Given this list of marker genes AGO1, BCR, MAPK8IP3, PRKDC, SMC3, TPR, CEP152, NAA80, PGAP3, MAPK1, OTUD6B, MAN1B1, WDR62, CDH11, AHDC1, OCA2, KCNJ2, SNRPN, THUMPD1, KATNB1, SHMT2, HDAC8 (histone deacetylase 8), MCPH1, TLK2, BCL11B, PIGG, SATB2, OCRL, LMBRD1, CHST14, WARS2, PDE4D, CRKL, TRPS1, ACBD6, HERC2, POGZ (NCBI Gene Id 23126), GAD1, AGL, PWAR1, KAT6A, TAF13, B3GLCT, PLPBP, PRKAR1B, TRRAP, ADAMTSL2, WAC, MED12L, TRAPPC10, IGF1R, TTC5, RNU4ATAC, CIT, ASCC3, WARS1, CEP63 (NCBI Gene Id 80254), SH3PXD2B, UBE3B, EBF3, CDK13, PIGV, TRMT10A (tRNA methyltransferase 10A), SLC6A1, KNL1, MBD5, ZNF526, NALCN, CDH2, UNC80, STT3A, SMARCC2, IFT43, TBL1XR1, PPP1CB, VPS35L, MKRN3, EIF5A, KCNMA1, KIF15, ATN1, ATRX, HK1, B4GALT1, SPECC1L, IFIH1, SRRM2, AMMECR1, PQBP1, PBX1, KAT6B, ANKRD11, MAGEL2, AARS1, SRCAP, PIGQ, PAK3, CDK10, KMT2D, ZNF407, SOX11, PHC1, AFF3, ATP6V1B2, PDGFRB, CTCF, PACS1, NCAPD3, ARMC9, SMARCB1, MPC1, ANKRD17, FAR1, METTL5, NIPBL, DHPS, MFSD2A, CDC42, TMEM147, CENPE, ACTG1, BMP2, ASXL2, AFF4, KDM5C, PURA, CNTNAP2, H4C5, CLTC, ARID1A, HIVEP2, GLIS3, MED12, NEXMIF, PIGU, COPB2, ADNP, DVL1, NAA10, BCL11A, MTOR, GNB2, CCNQ, PITX2, SMARCE1, ANKLE2, CLCN6, KIF14, RNF135, HNRNPC, SETD5, ALG12, TBCE, ALG9, CPLX1, AGR2, ZNF292, CEP295, BPTF, SPTBN1, CDC42BPB, SPEN, MED13, TBC1D24, ADGRG6, BUB1, SOX4, CHD2, USP9X, WASHC4, PUF60, KMT2A, ASPM, CASP2, NONO, KDM1A, GNAI1, OPHN1, CCNK, ZFX, FBN1, MCM7, PPP2R5D, EXT1, GJA5, RAP1B, SMARCD1, MEIS2, ARID1B, NPAP1, LAS1L, UBAP2L, AP3B1 (NCBI Gene Id 8546), SIM1, CREBBP, PTRH2, MCTP2, STIL, SMC1A, FIG4, CLP1, TAF6 (NCBI Gene Id 6878), WDR19, RNU4-2, ARX, PIEZO2, WDR26, PIGK, HS2ST1, VPS51, EP300, DCPS, SYNGAP1, FGFR2, DSE, CUX1, PYCR2, PGM2L1, DHX9, KDM3B, KDM6A, GATAD2B, PWRN1, MEF2C, POLR3A, SLC9A7, TNRC6B, IRX5, TRIO, CTNNB1, ADSL, CACNA1C, NOG, ACTB, ATIC, DDX59, PPM1D, GJA8, SASS6, KIF11, SYT1, PACS2, HUWE1, TCF20, TRIP12, SETBP1, SLC25A24, SLC2A1, RFX7, MYMX, TASP1, WNT5A, RPL10, NFIA, PSMD12, TRAPPC14, SIN3A, QRICH1, DPF2, PIGN, CEP135, DPM2, GNE, PCGF2, RALA (RAS like proto-oncogene A), CHAMP1, CDK6, MYO18B, RAD21, OGT, SNORD116-1, NUP37, PPP1R15B, DDB1, AP2M1, RHOBTB2, KCNJ5, ABCC9, SARS1 (NCBI Gene Id 6301), ARHGEF2, FBXO11, ASXL3, MAF, SEC23A, EDEM3, INTS11, EXOSC2, RAI1, MID1, ADARB1, CAPRIN1, CDK5RAP2, SCN1A, CNOT2, SLC26A2 (NCBI Gene Id 1836), ROR2, CSNK2A1 (NCBI Gene Id 1457), IRF6, CLCN3, TUBGCP2, SMPD4 (NCBI Gene Id 94852), SMAD4, DYRK1A, AGO2 (NCBI Gene Id 286109), ODC1, EXOC2, BCKDK, MKS1, COG1, STEEP1, SMARCA4, ZBTB18, PMM2, MAPRE2, ARID2, SNORD115-1, TAF1 (NCBI Gene Id 6872), KCNK4, ATP9A, SMARCA2, TRAPPC9, NDN, STAG2, TMEM94, FOXG1, here is a description of the gene set: studied in species Homo sapiens Human Gene Set: HP_THIN_UPPER_LIP_VERMILION Height of the vermilion of the upper lip in the midline more than 2 SD below the mean. Alternatively, an apparently reduced height of the vermilion of the upper lip in the frontal view (subjective). Thin upper lip vermilion